Given this list of marker genes BCO1, CYP27A1, CYP24A1, CYP2R1, PLTP, SNAI1, CYP27B1, SNAI2, IFNG, UBIAD1 (NCBI Gene Id 7801), TNF, CYP3A4, NFKB1, GFI1, here is a description of the gene set: The chemical reactions and pathways resulting in the formation of any of a diverse group of vitamins that are soluble in organic solvents and relatively insoluble in water. Human Gene Set: GOBP_FAT_SOLUBLE_VITAMIN_BIOSYNTHETIC_PROCESS studied in species Homo sapiens